Given this list of marker genes THOC2, THOC5, THOC1, THOC6, THOC7, THOC3, here is a description of the gene set: studied in species Homo sapiens Human Gene Set: GOCC_THO_COMPLEX The THO complex is a nuclear complex that is required for transcription elongation through genes containing tandemly repeated DNA sequences. The THO complex is also part of the TREX (TRanscription EXport) complex that is involved in coupling transcription to export of mRNAs to the cytoplasm. In S. cerevisiae, it is composed of four subunits: Hpr1p, Tho2p, Thp1p, and Mft1p, while the human complex is composed of 7 subunits.